Given this list of marker genes SEC11A, RBBP4, CD52, SINHCAF (SIN3-HDAC complex associated factor), CCDC90B, EIF5, R3HDM1 (NCBI Gene Id 23518), TARDBP, RAB5IF, PRP4K, CFAP20, MTRF1L, ST13, FTL, ZNF544, ATP5F1A, CCT3, DESI2, TOMM70, PLEKHJ1, DUT, CMTM6, C11orf21, GORASP2, RALA, SLC25A46, COMMD3, RAPGEF2, PLEKHA5, HSPA4, PPP2R2A, IL17RA, NREP, TTYH2, SMIM19, SEC23B, MRFAP1L1 (Morf4 family associated protein 1 like 1), SRPRB, TSPO, RRAGC, UBE2E1, GMFB, NAP1L1, PUM2, here is a description of the gene set: species: Homo sapiens Genes used to predict the clinical stages of acute T-cell leukemia (ATL): chronic vs acute. from publication Choi YL, Tsukasaki K, O'Neill MC, Yamada Y, Onimaru Y, Matsumoto K, Ohashi J, Yamashita Y, Tsutsumi S, Kaneda R, Takada S, Aburatani H, Kamihira S, Nakamura T, Tomonaga M, Mano H (PMID 16909099) Adult T-cell leukemia (ATL) is an intractable malignancy of CD4+ T cells that is etiologically associated with infection by human T-cell leukemia virus-type I. Most individuals in the chronic stage of ATL eventually undergo progression to a highly aggressive acute stage. To clarify the mechanism responsible for this stage progression, we isolated CD4+ cells from individuals in the chronic (n=19) or acute (n=22) stages of ATL and subjected them to profiling of gene expression with DNA microarrays containing >44,000 probe sets. Changes in chromosome copy number were also examined for 24 cell specimens with the use of microarrays harboring approximately 50,000 probe sets. Stage-dependent changes in gene expression profile and chromosome copy number were apparent. Furthermore, expression of the gene for MET, a receptor tyrosine kinase for hepatocyte growth factor (HGF), was shown to be specific to the acute stage of ATL, and the plasma concentration of HGF was increased in individuals in either the acute or chronic stage. HGF induced proliferation of a MET-positive ATL cell line, and this effect was blocked by antibodies to HGF. The HGF-MET signaling pathway is thus a potential therapeutic target for ATL. Human Gene Set: CHOI_ATL_STAGE_PREDICTOR